The following is a description of a gene set: studied in species Homo sapiens An abnormally increased sensitivity to the effects of ionizing radiation. Human Gene Set: HP_INCREASED_SENSITIVITY_TO_IONIZING_RADIATION Increased sensitivity to ionizing radiation, and this is the list of marker genes: NF2 (NCBI Gene Id 654093), TRAF7, SMARCE1, TERT, PIK3CA, SMO, PDGFB, BAP1, NSMCE3, RNF168, SMARCB1, SUFU, AKT1, MRE11